The following is a description of a gene set: Genes predicted to be targets of miRBase v22 microRNA hsa-miR-3934-3p in miRDB v6.0 with MirTarget v4 prediction scores > 80 (high confidence targets). studied in species Homo sapiens Human Gene Set: MIR3934_3P from publication Chen Y, Wang X (PMID 31504780), and this is the list of marker genes: ZIM3, MUC5B (mucin 5B, oligomeric mucus/gel-forming), CCT3, CD36, CNTN2, PABPC1, JOSD1, NAALADL2, DDX17, AMER1 (APC membrane recruitment protein 1), CHIC1, SMCR8, FCGR2A, NCDN, GAS2, NFASC, RIMS3, OSER1, SORT1, DHX8, SUSD2, LEF1, IMPG2, TPCN1, SYDE1, RSF1 (remodeling and spacing factor 1), FBXL20, DOK4, ZC3H7A, ANKIB1, TRRAP, MPZL3, CSRNP1, NPIPB11, NXF1, COPS6, ZNF516, EEIG1, TNFSF10, STYK1, CNBP, NPIPB13, OTOGL, BOK, LRRC20, ANKRD36B (NCBI Gene Id 80265), SENP1, CDC42SE2, SLC6A17, TMC1, NSFL1C (NCBI Gene Id 55968), C16orf92, CYP27C1, B3GAT3, ANKRD50, F9, HSPA9, NPIPB5, SNX27, DAZAP1, UNC5C, CPED1, FBXO9, GPRC5B, NPIPB4, GRIA3, C2CD3, OGT, SSTR2, GPR155, HMGXB3, NPIPB3, MED29, MOSMO, INHBC, PRIMA1, E2F7, CRTC1, TET3, TMEM196, TMEM106A (NCBI Gene Id 728772), BCL2L2, MTX3, ADAMTSL3, LNPK, RTN2, CCDC9B, NKAIN1, SDK2, GMFB, JADE1, CACNA1C, FGF14, ZZZ3, NID2, FST, PCYOX1, PROK1, PPP1R8, KCNS1, LUZP1, TRIM63, FAM168B